The following is a description of a gene set: Genes down-regulated similarly in primary fibroblast cultures from Werner syndrom patients and normal old donors compared to those from normal young donors. Human Gene Set: KYNG_WERNER_SYNDROM_AND_NORMAL_AGING_DN studied in species Homo sapiens Werner syndrome (WS) is a premature aging disorder, displaying defects in DNA replication, recombination, repair, and transcription. It has been hypothesized that several WS phenotypes are secondary consequences of aberrant gene expression and that a transcription defect may be crucial to the development of the syndrome. We used cDNA microarrays to characterize the expression of genes and ESTs across a panel of 15 primary human fibroblast cell lines derived from young donors, old donors, and WS patients. Of the analyzed genes, 6.3% displayed significant differences in expression when either WS or old donor cells were compared with young donor cells. This result demonstrates that the WS transcription defect is specific to certain genes. Transcription alterations in WS were strikingly similar to those in normal aging: 91% of annotated genes displayed similar expression changes in WS and in normal aging, 3% were unique to WS, and 6% were unique to normal aging. We propose that a defect in the transcription of the genes as identified in this study could produce many of the complex clinical features of WS. The remarkable similarity between WS and normal aging suggests that WS causes the acceleration of a normal aging mechanism. This finding supports the use of WS as an aging model and implies that the transcription alterations common to WS and normal aging represent general events in the aging process. from publication Kyng KJ, May A, Kølvraa S, Bohr VA (PMID 14527998), and this is the list of marker genes: PHKB, PDAP1, GSPT1, STAM, DAD1, UFD1, TGFBR2, SGK1, AMFR, MCM9, PDIA3, RND3, PDXDC1 (pyridoxal dependent decarboxylase domain containing 1), CDC123 (cell division cycle 123), WFDC2, SUMO1, TM4SF1, IL2RB, ST14, PDE6G, CDK2AP1, CYP3A7, ATP1B3, SLC35A1, IRF9, TFDP2 (NCBI Gene Id 7029), ADAR, GSTM4, PTH, FAM120A, NUCB1, METTL1, RIT1, TMEM187, DDT, TNRC6B (trinucleotide repeat containing adaptor 6B), ARPC2, LPIN1, MED22, STX5, THOC1, FGR (NCBI Gene Id 2268), AADAC, COASY (NCBI Gene Id 80347), COG2, IGF2R, MGAT2, ZNF440, ATP6V0A1, DYRK4, COPS5, MPI, CD8A, HCCS, BORCS8, USP4, POLR2J, ATP7A, FOXM1, GSTO1, KIF5B, PUDP, SLC6A12, CYTH1, DHCR24, RNPS1, USO1, HINT1, LINC02615, DDX17, KARS1, SRSF1, MYO18A, CSF3R, SDC4, DPF2, FCMR (Fc mu receptor), STK38, LGMN, CNN2, MNDA, ZBTB4, MORC3, TRDN, ROPN1L, AAMP, SMARCB1, CAPZA1 (NCBI Gene Id 829), CDC27, GRB2, TUBA4A (NCBI Gene Id 93373), ALDH6A1, GGT5, POLRMT, FGFR2, MCFD2, AIP, PLEKHG5, CBX3, PSEN1, NEDD4, RGN, SPINT2, SERPINB9P1, TXNRD1, ABR, ZFP36L2, KCTD4, UBE2N, CKAP5, RPL28, TJP2, C17orf99, ZC3HAV1L, MAP2K4, PCP4, CLK2, PSMA5, MTCL1, ARPC1A, LRRIQ3, SLC25A16, EPB42 (NCBI Gene Id 2038), ARHGDIB, MED13L, BMAL2, ALAS2 (NCBI Gene Id 90735), AMMECR1, HS6ST1, MADD, IGF2, SLAMF8, USP6NL, IGFBP6, CYFIP1, GFAP, ZNF32, DGKA, BAP1, ECE1, BEX2, GM2A, DKK3, ASMT, BDNF, BCL2A1, POLR2A, SDHAP1, ZNF449, DPM1, SMARCA1, LRRC17, EIF2AK1, BABAM2, ZSCAN9, CUL2, NEURL1, MRPL4, HNRNPH1, MYL6, TMEM263, PMS2P1, PSG1, ZNF629, SFTPA2, PPP6C, HNRNPF, BAZ2A, CMTR1, SNRPD2, SLC16A2, PRCC, PVALB, CKMT1B, FXN, MIA3, SAV1, CLDN10, CACNA1D, INPPL1, CCT2, ADCY7, VKORC1L1, CCL14, BECN1, DRAP1